The following is a description of a gene set: Human Gene Set: HP_NYSTAGMUS Rhythmic, involuntary oscillations of one or both eyes related to abnormality in fixation, conjugate gaze, or vestibular mechanisms. species: Homo sapiens Nystagmus, and this is the list of marker genes: TAF1, SLC19A2, INPP5E (NCBI Gene Id 56623), PDE6A, SIL1, PITPNM3, PEX13, WDR73, SREBF1, DNAJC12, SMC1A, WDR45, NSD1, TAOK1, IFT27, TRAK1, TMEM126B, CEP104, SLC45A2, FANCL, ZFYVE26, OPN1MW, BUD23 (BUD23 rRNA methyltransferase and ribosome maturation factor), RNU4ATAC, OPA3, SAMHD1, ARNT2, HGSNAT, RFWD3, PALB2, ROM1, WDR48, MVK, NIPBL, PSAP, CLCN7, KCNC2, PRRT2, SYNJ1, SACS, RNU7-1, ATP6V1E1, SYNGAP1, SLC29A3, GABRD, AP3D1, MRE11, PCYT1A, MAK, ELOVL4, RAD21, SLC19A3, SYNE1, CLN5, AGBL5, MPC1, TMEM231, ADPRS, LYST, CNTNAP2, COL13A1, ZNF423, AP3B1, FOXC1, IMPG1, EYS, GDF6, CPSF3, SEMA3E, ESCO2, ATP5F1D, PROKR2, GRK1, BRCA2, PRCD, SLC52A2, FSCN2, FANCF, COL18A1, SLC5A6, SERPINI1, GRM6, ERMARD, ATP1A2, ROBO1, EDNRB, IFT122, MICOS13, PEX10, CRYGD, PDE6H, ELOVL5, COG4, VRK1, NRL (neural retina leucine zipper), BUB1B (NCBI Gene Id 701), SLC12A6, NANS (NCBI Gene Id 54187), PRPH2, DPAGT1, KCNH1 (NCBI Gene Id 8656), ELN, OFD1, SYT2, STUB1, NECAP1, BBS10, KLHL7, CLTC, FANCM, RLBP1, CBY1, SPG11, PRDM16, XRCC2, PTPN11, PRPF6 (pre-mRNA processing factor 6), EXOSC8, POLR3K, CHKA, CASZ1, LAMB2, UBE3B, GJB1 (gap junction protein beta 1), PI4KA, ACO2, RASA2, LAGE3, COL11A1 (collagen type XI alpha 1 chain), NDUFS3, LZTR1, MAD1L1, GPR179, NSUN2, GTF2I, CACNA2D1, TBCD, FANCE, NDUFB10, SIX6, PAX2, SCUBE3, PRKD1, SCN1A, OTX2, RAB18, RNASET2, VPS37D, GALC, RDH12, NDST1, MAB21L2, DEGS1, CENPE, PDE6D, NEFL, SON, MTR, SLC39A8, TTC8, TMEM216, BRAT1, ANKH, CNOT3, NUBPL, GCH1, SLC24A1, MRPS34, MYO7A, FOXL2, CYP7B1, ATP2B3, ANOS1, TAF2, SLC4A11, UBE4B, UROC1 (urocanate hydratase 1), CNGB3, HUWE1, BAZ1B, TUBGCP6, NDUFB9, SKI, ROBO3, PLXNA1, SNRPN, ALDH18A1, ATG5, SALL2, LRAT, CNGA3, MAPK8IP3, NDUFAF4, TOE1, PDP1, SPAST (spastin), SPTAN1, HID1, CEP164, HESX1, TIMMDC1 (NCBI Gene Id 51300), CLTRN, ERCC3, PRSS12, TYR, LARGE1, GNAT2, MOCS2, MT-ND3, CLCN6, KCNN2, SH3TC2, HPS1, TRPM1, FOXP1, SNIP1, CSF1R, FANCA, GOSR2, SOS1, SCAPER, EXTL3, EXOSC9, CASK, TCTN1, KCNMA1, KCNAB2, HK1, TBL2, RAD51C, CACNA1A, IFT52, GNB1, TRIM32, KIZ, MRPL12, PDE6C, CYP1B1, LMBRD2, SDHA, BRIP1 (NCBI Gene Id 83991), SLC2A1, UBA5, USP8, PIGG, GLRX5, GTF2E2, TMEM240, ERCC8, SLC17A5, NDUFA6, COG3, PIGS, POLG, CERS1, ARMC9, DOHH, SPTBN2, ALG1, SLC1A2, FANCB, NDUFAF1, NDUFAF8, DOLK, AFG3L2, METTL27, CNGB1, KATNIP, GTF2IRD1, PRKCZ, GABBR1, KRAS, BEST1, EMC10, VAMP1, SLC9A6, RFX7, ZNF699, GUCY2D, EGR2, RAB11B, MOCS1, OCA2, KCND3, SOX10, GMPPB, ALX4, NDUFV1, CHAT, HNRNPH1, PITX2, PACS2, BCAS3, RGS9BP, EXOSC5, LETM1, CWF19L1, CTDP1 (CTD phosphatase subunit 1), ADD3, GJA8 (gap junction protein alpha 8), TFAP2A, BLOC1S3, U2AF2, POC1B, OCRL, MKKS, COQ5, SCN8A, PLEKHG2, NDUFS7, MME, PEX5 (peroxisomal biogenesis factor 5), OSGEP, ARL13B, STX1A, MMP23B, TMEM63C, ASH1L, SPRED2, KRT10, PTPN22, USP45, LYRM7 (LYR motif containing 7), FMR1, MT-ATP8, TTR, OPN1LW, SDHB, SLC33A1, MT-ND1, PLAA, CRIPT (CXXC repeat containing interactor of PDZ3 domain), GTF2IRD2, MN1, B9D2, GNAS, EXT2, CRB1, EFNB1, TUBGCP4, MT-ND6, GRIK2, CREBBP, PRDX1, ADGRG1 (NCBI Gene Id 9624), XYLT2, GBA1, AHDC1, HS6ST1, KCNV2, TAT, REPS1, APC2, LIMK1, NSD2, SPATA7, HNRNPR, TCTN3, RFC1, ABCA4, PPP1CB, ATPAF2, AIMP1, SPTBN4, TELO2, PIGT, PSMD12, SCN2A, SAMD9L, NDUFB11, AGTPBP1, LRP5, PRPS1, TGM6, RIMS2, HPS6, SOX3, ATXN8OS, MAB21L1, PPOX (protoporphyrinogen oxidase), TONSL, TMEM163, RHO, SCO2, PEX2, NPTX1, DPM1, RTN4IP1, NOP56, TCTN2, SDCCAG8, AGRN (agrin), PEX16, NT5C2, RP1L1, PRPF3, PMM2, RIT1, NDUFAF2, CAPN1, NADK2, HMBS, POLR3B, TKFC, HSD17B4, EEF2, DCT, DHX37, AGK, RBL2, NOTCH2NLC, PARS2, FBN1, TUBB4B, IDH3B, CPLANE1, NDNF, CRLS1, TAF6, FZR1, NDUFA1, MTHFR, RNASEH2B, HARS1, MARS2, SLC1A3, GJA1 (gap junction protein alpha 1), KIF7, KRT14, BRAF, YARS2, PIGN, TUBB4A, SPRY4, MAF, LMNB1, PNPLA6, SOST, NFIX, NCF1, KIF5A, GRIN2D, TMEM237, SRD5A3, TRAPPC6B, FANCG, FLRT1, MT-TK, TUB, ERCC4, ATXN2, SNX14, DNMT1, TMEM126A, PCARE, DARS1, TOPORS (NCBI Gene Id 641432), YARS1, MAG, NAA10, ABCB7, CLIP2, SIN3A, FGF8, DGUOK, RD3, RECQL4, TBC1D24, MT-ND4, VPS41, ANO10, KIAA0753, ABHD12, SURF1, GABRA5, NDUFB3 (NCBI Gene Id 4709), IL17RD, MAP2K2, NCAPG2, FAM149B1, CC2D2A, THG1L, FGFRL1, MED12, FOXG1, DPP6, MYO5A, NAXE, GPR143, TET3, ALG3 (ALG3 alpha-1,3- mannosyltransferase), TRAF3IP1, CRYBB2, PAX6, REEP6, RPIA, EIF2S3, LAMA1, RAP1B, WDR35, PPP1R21, DKK1, TANGO2, UBAP1, TWNK, AHI1, KCNC3, ANK1, KIAA1549, KRT5, SLC7A14, KCNJ13, FKBP6, AFF3, ATXN7, CACNA2D2, MAN2B1, TMEM270, CCDC141, NAGLU, ATF6, TREX1 (NCBI Gene Id 82474), CCDC28B, FDXR, AP3B2, SYT1, SPEN, CERKL, FASTKD2, P4HTM (prolyl 4-hydroxylase, transmembrane), BBS9, CEP78 (NCBI Gene Id 84131), ARHGEF2, VPS33A, CEP290, TYRP1, ASPA, MAFB, EIF3F, CLPB, CRX, SNAP25, NR2E3, UBE2T, CTNNB1, HIBCH, CLDN11, SLC16A2, POGZ, MPDZ, CNNM4, ARHGEF18, ERCC6, FANCI, UCHL1, PROM1, KCNB1, TMEM63A, DHCR7, FRMD5 (FERM domain containing 5), MCAT (NCBI Gene Id 91700), SLC25A24, NSUN3, CAV1, GRM1, RIMS1, PGAP1, DRAM2, FGF17, NR2F1, ATXN3, SLC18A3, MAP2K1, ATP5MK, KCNK4, CLP1, UBE3A, ABHD5, PRDX3, FAM161A, CACNB4, TTPA, CLTCL1, PIK3R5, PBX1, GDAP2, FOCAD, NHS, CEP41, FDX2, CLRN1, ERLIN2, CRYBA4, RIPOR2, SNX10, BRCA1, HPDL (4-hydroxyphenylpyruvate dioxygenase like), OSTM1, VPS13B, ESAM, KIF2A, HDAC8, SLC25A20, TUFM, MTRFR, MT-ATP6, GMPPA, EPG5, NDUFS2, TOMM7, MTRR, SLC24A5, PRPF31, GFAP, MPLKIP, NTRK2, PRDM13, L2HGDH, RPGRIP1L, NARS2, GFER, MKS1, ERCC1, BEAN1, MINPP1, RNF113A, MMACHC, OPA1, SLC25A46, CACNA2D4, EIF4H, PURA, PEX7, KDM6A, SRPX2, PHF6, BBS4, TINF2, MTSS2, CACNA1F, IDH1, MYO9A, EBP, OPN1SW, CRYAA, GABRA2, LCA5, NTNG2, OPHN1, NDUFV2, ARID1B, TDP1, NKX6-2, PPP3CA, FRMPD4, NDUFAF5, HSPG2, LZTFL1, BLOC1S6, MMADHC, IFT88, NAGA, DAB1, USH2A, DARS2 (aspartyl-tRNA synthetase 2, mitochondrial), ATP6V1A, PET100, ATP6V1B2, POU3F4, IBA57, MAPKAPK5 (NCBI Gene Id 8550), OGT (O-linked N-acetylglucosamine (GlcNAc) transferase), MPDU1, HCN1, SQSTM1, APTX, CBL, IQCB1, SPG7, DLAT, BDNF, FOXE3, SOS2 (SOS Ras/Rho guanine nucleotide exchange factor 2), MPV17, UNC80, CHD8, RUBCN, EEF1A2, CYP27A1, TRIM44, GFM1, GBA2, CA4, TARS1, YAP1, TCEAL1, CPLX1, PUS3, PEX6, CDK19, CNGA1, WDR19, PLA2G6, GALNT2, TRPV6, TTC19, GABRB2, FCSK, IFT43, B4GALNT1, OXR1, ADAR, GABRA3, TNFSF11, TUBA1A (NCBI Gene Id 95407), SEMA3A, WDPCP, NEK2, DHDDS, PHYH, SCLT1, HSD17B10, L1CAM, NDUFAF3, PORCN, WT1, MCOLN1, FLRT3 (fibronectin leucine rich transmembrane protein 3), B3GLCT, DHX38, GUCA1B, HSPD1, TNFRSF11A, IFRD1, MTPAP, PEX26, GATA3, CARS1 (NCBI Gene Id 833), BBS5, RRAS2, SLC38A3, PAK2, ATCAY, PRPF4, PEX12, NELFA, ERCC2, UBAP2L, RPGR, POLR3A, PRPF8, VPS13D, SLC25A1, WDR11, FRMD7, ATP13A2, SDHAF1, TTLL5, SMPD1, SAG, PEX11B, BBS1, NDUFS6, CNKSR2, CEP19, UGP2, SPART, ALG13, GPAA1, SRY, COQ4, LRMDA, GNAT1, TRIP13, PDPN, EP300, NUS1, WFS1, PNPT1, DNAJC30, ADAMTSL4, BBIP1, RP2, TUBB3, THOC2, ACBD5, SLC6A6, CACNA1G, SEMA4A, KMT2D, COX15, PNPO, RNASEH2A, ZNF513, PMP22, CLCN3, SMC3, CAMK2B, RPGRIP1, ELOVL1, HLA-B, IGBP1, RHOA, ATN1, NUP62 (nucleoporin 62), GNB5, LRP4, LRPPRC (leucine rich pentatricopeptide repeat containing), POLR1A, RAD51, ERCC5, DEPDC5, POMGNT1, FANCD2, IMPDH1, EXOSC2, CHD6, YWHAG, BLOC1S5, NRAS, ATP5F1A, PPP2R5D, KCNA2, ALG2, RORA, RAB28, PDZD7, GAN, HMX1, H3-3A, PLP1, HMGB3, JAM2, COX10, TBCK (TBC1 domain containing kinase), MED11, ADGRV1, MT-TL1, ATXN1, IFIH1 (interferon induced with helicase C domain 1), BBS2, SYT14, ANTXR1, DCC, RAF1, PHGDH, NDUFA11 (NADH:ubiquinone oxidoreductase subunit A11), ITPR1, CACNA1E, NFU1, UNC119, RNASEH2C, ENSG00000288330, FUS, ATM, FA2H, TOGARAM1, P4HA2, NUP54, SOX2, PRX, MYT1L, FXN, GRIA4, DNM1L, ADAM9, MT-ND5, PYCR2 (NCBI Gene Id 29920), WARS2, CACNA1B, KANK1, ALMS1, DPYD, STX16, TBP, LIM2, RAX2, NR4A2, SLC35A1, RPE65, CABP4, KIF1A, AIPL1, FBXO28 (NCBI Gene Id 23219), MPZ, NPHP4, PPFIBP1, NDUFS1, IMPG2, DNM1, OCLN, TULP1, TENM3, VLDLR, GTF2H5, NDUFS8, ATP5F1E, ZFX, FGFR1, PRR12, NDP, MT-TW, CRYBB1, PDGFRB, WNK3, NYX, ATAD3A, DCX, CDHR1, OTUD5, PLK4 (polo like kinase 4), MBTPS2, FRRS1L, FEZF1, ARX, RBP3, TMEM218 (NCBI Gene Id 219854), PEX1, KLC2, IDH3A, CRYGC, HLA-DRB1, FGF12, ACTL6B, IFT172, PIGU, IMPDH2, SCN3A, ZNF408, SDHD, HPS5, RRAS, SLC6A19, ALG8, FBXL4, ARL3, PANK4, ATXN10, KIDINS220, TTBK2, SLC9A1, BBS12, KIF1C, LRIT3, RP1 (RP1 axonemal microtubule associated), SLC13A5, SLC25A4, IPO8, USP7, NDUFS4, PRNP, TMEM138, PDE6G, SETX, LUZP1, MRAS, TEFM, CEP120 (centrosomal protein 120), DNMBP, KMT2B, ALS2, BBS7, VWA3B, CISD2, DDB1, PIGL, CYFIP2, STX3, NMNAT1, POU4F1, SNF8, ABCC9, TSPAN7, SLC38A8, DALRD3, RFC2, ACBD6, AHR (NCBI Gene Id 196), TACR3, TMEM106B, ARL6, PCYT2, MAD2L2, SNRNP200, CLDN16, PHIP, CP, ECHS1, HPS3, CRELD1, FANCC, PTCD3, AFG2A, CELF2, PROK2 (NCBI Gene Id 60675), NEU1, WWOX, LIG4, GRID2, SLX4, TCIRG1, PEX19, LONP1 (lon peptidase 1, mitochondrial), RNU4-2, COQ2, DHCR24, FZD5, RERE (arginine-glutamic acid dipeptide repeats), TPP1, GNB3, PLD3, CLDN19, EXOSC3, ATP1A3, CSPP1, MERTK, DTNBP1, HYLS1, GABRG2, CHD7, NALCN (NCBI Gene Id 93074), HTRA1, CFAP410, XRCC1, PRKCG, SUPT16H, ANKRD11, GJC2, SLC35A2, ATOH7, KARS1, XRCC4, GDF3, DUSP6, RGR, WHRN, PIGQ, AARS2, ASAH1, PAX7 (paired box 7), CHN1, RNF216, PIBF1, BCOR (BCL6 corepressor), KIF11, FGF14, GABBR2, SLC35B2, SALL4, AIFM1, ARL2BP, GUCA1A, PACS1, PHF21A, SZT2, TLCD3B, FAT2, MT-TV, APC, MECR, BMP4, CFAP418, RARS1, PMPCA, CDH3, IFT74, TMEM67, CTBP1, NPHP1, EPRS1, RP9, CAMTA1, USH1C, IQSEC2, TBL1XR1, HIKESHI, NEDD4L, LSM11, AARS1, MTFMT, ADSL, IFT140, ISCA2, ZNF292, HECW2, IARS2, PEX3, FOXRED1, PDE6B, SIGMAR1, IRF2BPL, PEX14, KIAA0586, BRD4, SPTLC1, MC1R, B9D1, HPS4 (HPS4 biogenesis of lysosomal organelles complex 3 subunit 2), ACOX1, SLC5A7, TPK1, SUFU, MT-ND2, AP4E1, RNU12